Given this list of marker genes Abcb1a, Ripk1, Tcaf1, Gopc, Abcb1b, Cftr, Mtor, here is a description of the gene set: Any process that modulates the frequency, rate or extent of anion transmembrane transport. Mouse Gene Set: GOBP_REGULATION_OF_MONOATOMIC_ANION_TRANSMEMBRANE_TRANSPORT species: Mus musculus